The following is a description of a gene set: studied in species Mus musculus Any process that modulates the frequency, rate or extent of enamel mineralization, the deposition of calcium salts in tooth enamel. Mouse Gene Set: GOBP_REGULATION_OF_ENAMEL_MINERALIZATION, and this is the list of marker genes: Dicer1, Tgfb1, Dmp1, Amtn, Cftr, Dspp, Slc4a2, Enam, Odaph